The following is a description of a gene set: A G protein-coupled receptor signaling pathway initiated by thrombin binding to its receptor on the surface of a target cell, and ending with the regulation of a downstream cellular process. Human Gene Set: GOBP_THROMBIN_ACTIVATED_RECEPTOR_SIGNALING_PATHWAY studied in species Homo sapiens, and this is the list of marker genes: GP1BA, PLEK (NCBI Gene Id 5341), F2RL1, VPS54, MET, DGKQ, STMN1, F2R, F2RL2, SNCA, IQGAP2, F2RL3, HPGD, F2